The following is a description of a gene set: The series of molecular signals initiated by collagen binding to a cell surface receptor, and ending with the regulation of a downstream cellular process, e.g. transcription. Mouse Gene Set: GOBP_COLLAGEN_ACTIVATED_SIGNALING_PATHWAY species: Mus musculus, and this is the list of marker genes: Ubash3a, Epha6, Oscar, Ubash3b, Syk, Enpp1, Col4a5, Epha2, Fgfr4, Pdgfra, Ephb2 (Eph receptor B2), Mertk, Epha8, Ror2, Pdgfrb, Kdr, Tspan9, Erbb2, Csf1r, Erbb4, Epha3, Insrr, Jak2, Itga2, Alk, Musk, Col4a6 (NCBI Gene Id 94216), Tek, Epha4, Flt4, Col4a2, Ros1, Ephb3 (Eph receptor B3), Mst1r, Epha10, Ddr1, Tie1, Fgfr1, Flt1, Ntrk2, Ephb1, Epha1, Tyro3, Egfr, Kit, Ltk, Epha5, Ntrk3, Col4a3, Met, Ntrk1, Flt3, Fgfr3, Ret, Insr, Col4a1, Ddr2, Col1a1, Gp6, Fgfr2 (fibroblast growth factor receptor 2), Axl, Epha7, Ephb4, Itga11, Igf1r